The following is a description of a gene set: species: Homo sapiens Any process that modulates the frequency, rate or extent of oligodendrocyte differentiation. Human Gene Set: GOBP_REGULATION_OF_OLIGODENDROCYTE_DIFFERENTIATION, and this is the list of marker genes: TENM4, ZNF488, TMEM98, ID4, TNFRSF1B, ID2, MTOR, DLX2, WDR1, HDAC1, TNFRSF21, ZNF365, RHEB, NKX6-1, PTN, SLC45A3, CTNNB1, OLIG2, CLCN2, SOX1, DAAM2, NKX2-2, MDK, MYRF, DLX1, DUSP10, HES1, PRMT5, DRD3, OPALIN, NOTCH1, HDAC2, PTPRZ1, TP73, NF1 (neurofibromin 1), GSX2, DAG1, QKI, DUSP15, NKX6-2, HES5, CXCR4, IL34, SHH